Given this list of marker genes ESR1, FOXP3, RUNX1, CBFB, AXIN1, RSPO3, here is a description of the gene set: studied in species Homo sapiens RUNX1 regulates transcription of genes involved in WNT signaling Human Gene Set: REACTOME_RUNX1_REGULATES_TRANSCRIPTION_OF_GENES_INVOLVED_IN_WNT_SIGNALING